Given this list of marker genes CRHBP, HLA-DQB1, PCDH9, PROM1, HLA-DQA1, LTB, GZMB, TM4SF1, CEP15, JCHAIN, here is a description of the gene set: Genes down-regulated in dividing CD34+ cells isolated from peripheral blood of CML (chronic myeloid leukemia) patients compared to the dividing cells from normal donors. Human Gene Set: GRAHAM_CML_DIVIDING_VS_NORMAL_DIVIDING_DN from publication Graham SM, Vass JK, Holyoake TL, Graham GJ (PMID 17717066) studied in species Homo sapiens Quiescent and dividing hemopoietic stem cells (HSC) display marked differences in their ability to move between the peripheral circulation and the bone marrow. Specifically, long-term engraftment potential predominantly resides in the quiescent HSC subfraction, and G-CSF mobilization results in the preferential accumulation of quiescent HSC in the periphery. In contrast, stem cells from chronic myeloid leukemia (CML) patients display a constitutive presence in the circulation. To understand the molecular basis for this, we have used microarray technology to analyze the transcriptional differences between dividing and quiescent, normal, and CML-derived CD34+ cells. Our data show a remarkable transcriptional similarity between normal and CML dividing cells, suggesting that the effects of BCR-ABL on the CD34+ cell transcriptome are more limited than previously thought. In addition, we show that quiescent CML cells are more similar to their dividing counterparts than quiescent normal cells are to theirs. We also show these transcriptional differences to be reflected in the altered proliferative activity of normal and CML CD34+ cells. Of the most interest is that the major class of genes that is more abundant in the quiescent cells compared with the dividing cells encodes members of the chemokine family. We propose a role for chemokines expressed by quiescent HSC in the orchestration of CD34+ cell mobilization. Disclosure of potential conflicts of interest is found at the end of this article.